The following is a description of a gene set: Human Gene Set: GOBP_EXOCYST_LOCALIZATION Any process in which an exocyst is transported to, or maintained in, a specific location. An exocyst is a protein complex peripherally associated with the plasma membrane that determines where vesicles dock and fuse. studied in species Homo sapiens, and this is the list of marker genes: EXOC3L1, RALB, TNFAIP2, RALGAPA2, EXOC3, EXOC3L4